The following is a description of a gene set: Human Gene Set: MIR5586_5P Genes predicted to be targets of miRBase v22 microRNA hsa-miR-5586-5p in miRDB v6.0 with MirTarget v4 prediction scores > 80 (high confidence targets). from publication Chen Y, Wang X (PMID 31504780) species: Homo sapiens, and this is the list of marker genes: TXNL1 (thioredoxin like 1), TRMT11, PALMD, C10orf90 (NCBI Gene Id 118611), GNAQ, LGALSL, RASA1 (RAS p21 protein activator 1), USP49, DSC3, KRTAP1-5, HNRNPR, FAM89B, KLHL31, ARHGAP12, DEGS1, GLIS3, NUAK1, RAD23B, MBTD1, LRRC31, ABRAXAS1, DLX5, IGLON5, NOL3, ITCH, STAG2, TMOD1, ARHGAP24, MGAT4A, HMGN2, RGS7, TRABD2B, KLHL42, ZNF324B, USP9Y, ENPP1, KLHL32, LRRK1, RIT2, SLCO5A1, TRMT5, ELN, HOXA1, SNX4, JADE1, PURA, LCP1, TNRC6B, CCDC126, BLZF1 (NCBI Gene Id 8548), PRELID3A, PRRC2C, CC2D2B, ATRN, DERL1, AGPAT1, ACTN4, AIM2, POMGNT1, LMO3, SUSD6, MYL12B, COPS4, ZNF215, HTATSF1, EIF2AK2, TFRC, SVEP1, OTOR, MITF, MAGI3, NR3C1, PRDM15, HIVEP2, PCDHGB5, PTPN12, RIN2, CNOT6, FOXO1, INTS6L